The following is a description of a gene set: Genes up-regulated in medullary breast cancer (MBC) relative to ductal breast cancer (DBD). Medullary breast cancer (MBC) is a rare but enigmatic pathologic type of breast cancer. Despite features of aggressiveness, MBC is associated with a favorable prognosis. Morphologic diagnosis remains difficult in many cases. Very little is known about the molecular alterations involved in MBC. Notably, it is not clear whether MBC and ductal breast cancer (DBC) represent molecularly distinct entities and what genes/proteins might account for their differences. Using whole-genome oligonucleotide microarrays, we compared gene expression profiles of 22 MBCs and 44 grade III DBCs. We show that MBCs are less heterogeneous than DBCs. Whereas different molecular subtypes (luminal A, luminal B, basal, ERBB2-overexpressing, and normal-like) exist in DBCs, 95% MBCs display a basal profile, similar to that of basal DBCs. Supervised analysis identified gene expression signatures that discriminated MBCs from DBCs. Discriminator genes are associated with various cellular processes related to MBC features, in particular immune reaction and apoptosis. As compared with MBCs, basal DBCs overexpress genes involved in smooth muscle cell differentiation, suggesting that MBCs are a distinct subgroup of basal breast cancer with limited myoepithelial differentiation. Finally, MBCs overexpress a series of genes located on the 12p13 and 6p21 chromosomal regions known to contain pluripotency genes. Our results contribute to a better understanding of MBC and of mammary oncogenesis in general. studied in species Homo sapiens Human Gene Set: BERTUCCI_MEDULLARY_VS_DUCTAL_BREAST_CANCER_UP from publication Bertucci F, Finetti P, Cervera N, Charafe-Jauffret E, Mamessier E, Adélaïde J, Debono S, Houvenaeghel G, Maraninchi D, Viens P, Charpin C, Jacquemier J, Birnbaum D (PMID 16651414), and this is the list of marker genes: PSAP, ATXN7, CEBPD, NME3, C1RL, C1RL-AS1, CDCP1, PLCL2, ME2, BIRC3, SNHG26, LAP3, BTN3A1, MRTO4, NFKBIE, DHX34, PHF19, MCM10, TYSND1, FBL, ZFP42, TRAF3, CTSS, ATP8A1, NOP16, GBP5, DTX3L (deltex E3 ubiquitin ligase 3L), ITGB7, POGLUT1, KBTBD8, C2CD2, PQBP1, ADAM8, FAM53B, GBP4, DAZAP1, TAP1, BMAL2, ZNF512B (NCBI Gene Id 57473), SKAP1, SNHG12, GRWD1, SRGN, NBN, TEAD4, NUP93, MCMBP, ICAM1, INTS13, ZMIZ2, DESI1, PLGRKT, HERPUD1, GALM, ETV7, GLRX, IFI30, ABCC4, AIFM2, CD38, RFX5, STYK1, BHLHA15, LARS1, APOE, CUL2, TRABD, FERRY3, DNAJC9, HEATR1, HSH2D, RARS1, GABBR1, NFE2L3, ELL, PARVB, MIR155HG, MAP2K1, PSMB2, TCOF1, CD274, CASP10, RAP2B, BUB3, PIM2, BTN3A3, EEF1AKMT4, CASS4, TAPBPL, CBS, EMG1, HLA-DOB, CCDC69, PSMB9, AGMAT, CDCA3, KLRC1, CHCHD1, GRK3, E2F5, TRAFD1, AIM2, HCP5, TIAL1, STAT1 (signal transducer and activator of transcription 1), YBX3, DDX50, PSMA5, CENPA, RILPL2 (NCBI Gene Id 196383), PSMB10, HSPA4, PPA1, IL15, SOCS3, ERO1B, SEC23IP, XPNPEP1, GTSE1, DRAM1, CGAS, TNFAIP2, ANKRD22, SLC4A1AP, TNFRSF1B, IL15RA, MICB, SCML1, RELB, RCL1, PARP8, PRR13, PCSK6, PPP1R15B, LAG3, ETV6, IL27RA, STAMBPL1, VCAM1, ZCCHC9, CCDC88C, NR1H3, PSMG4, PTPN6, SLC2A6 (solute carrier family 2 member 6), PCOLCE2, IL32, ISCU, SLC7A1, TYMP, MKI67, NCF1, SIAH2, FOXM1, CALHM6, C1S, ADORA2A, AFG2B, MINPP1, CLEC2D, NOP2, CYBA, TREX1, FOXJ2, CLEC7A, RGS1, ERAP1, GABPB1, RASGEF1A, NFKB2, IGLC2, FBRSL1, LINC00869, SOD2, MAGOHB, PNKD, TLR2, NOC3L, SGPL1, IRF1 (NCBI Gene Id 96501), RNF207, ASPHD2, CEP55, PHB2, TAGAP, GYG1 (glycogenin 1), RIMKLB, PUS1, ANXA7, PSMB8, EPB41, GZMA, NSMCE4A, TMX2 (thioredoxin related transmembrane protein 2), TNFRSF14, C9orf72, ACSL5, IQCG, ABCA3, MYNN, PPIF, M6PR, EME2, RPS21 (NCBI Gene Id 6227), C1orf174, WARS1, IL12RB1